Given this list of marker genes Sox9, Agtr1a, Id4, Scnn1a, Ptgr1, here is a description of the gene set: Early prostate development genes (down-regulated at 48 hr dihydrotestosterone) which are also down-regulated in high grade prostatic intraepithelial neoplasia (PIN) vs invasive cancer. from publication Schaeffer EM, Marchionni L, Huang Z, Simons B, Blackman A, Yu W, Parmigiani G, Berman DM (PMID 18794802) species: Mus musculus Mouse Gene Set: SCHAEFFER_PROSTATE_DEVELOPMENT_AND_CANCER_BOX6_DN Cancer cells differentiate along specific lineages that largely determine their clinical and biologic behavior. Distinct cancer phenotypes from different cells and organs likely result from unique gene expression repertoires established in the embryo and maintained after malignant transformation. We used comprehensive gene expression analysis to examine this concept in the prostate, an organ with a tractable developmental program and a high propensity for cancer. We focused on gene expression in the murine prostate rudiment at three time points during the first 48 h of exposure to androgen, which initiates proliferation and invasion of prostate epithelial buds into surrounding urogenital sinus mesenchyme. Here, we show that androgen exposure regulates genes previously implicated in prostate carcinogenesis comprising pathways for the phosphatase and tensin homolog (PTEN), fibroblast growth factor (FGF)/mitogen-activated protein kinase (MAPK), and Wnt signaling along with cellular programs regulating such 'hallmarks' of cancer as angiogenesis, apoptosis, migration and proliferation. We found statistically significant evidence for novel androgen-induced gene regulation events that establish and/or maintain prostate cell fate. These include modulation of gene expression through microRNAs, expression of specific transcription factors, and regulation of their predicted targets. By querying public gene expression databases from other tissues, we found that rather than generally characterizing androgen exposure or epithelial budding, the early prostate development program more closely resembles the program for human prostate cancer. Most importantly, early androgen-regulated genes and functional themes associated with prostate development were highly enriched in contrasts between increasingly lethal forms of prostate cancer, confirming a 'reactivation' of embryonic pathways for proliferation and invasion in prostate cancer progression. Among the genes with the most significant links to the development and cancer, we highlight coordinate induction of the transcription factor Sox9 and suppression of the proapoptotic phospholipid-binding protein Annexin A1 that link early prostate development to early prostate carcinogenesis. These results credential early prostate development as a reliable and valid model system for the investigation of genes and pathways that drive prostate cancer.